The following is a description of a gene set: species: Homo sapiens Human Gene Set: WP_MAMMARY_GLAND_DEVELOPMENT_PREGNANCY_AND_LACTATION_STAGE_3_OF_4 Mammary gland development: pregnancy and lactation - stage 3 of 4, and this is the list of marker genes: STAT5A, DLGAP4 (DLG associated protein 4), PNCK, PTPN1 (NCBI Gene Id 5770), CEBPA, TFPI2, NFIC, TNFSF11, ORAI1, PRL, HDGFL2, JAK2, NRG1, EIF4G1, ERBB2, CHUK, CLDN6, YY1, NR3C1, EGFR, NFIX, ERBB3, GAL, CEBPB, EIF4E, ERBB4, NFIB, USF1, ESR2, BCL2L1, TNFRSF11A, MYC, USF2, CCND1, CAV1, ATP2C2, NFIA, ESR1, PGR, TTC9, CSN2, GJB2, PRLR, TPM3 (tropomyosin 3), ELF5, STAT5B